Given this list of marker genes NMT2, INTS2, CEP170 (centrosomal protein 170), CNOT6, MMD, TENT4B, KCNMA1, GCLC, CSMD3, TDRD5, PTPRT, TTC13, CCDC138, TBC1D19, GALNT1 (NCBI Gene Id 2589), PPARGC1A, LAMC1, PDZRN3, AP3B1, PCCB, ABCB9, BPTF, FBXO48, MIER1, EPHA7, WTAP, PI4KAP2, TOP1, HOXA5, FBXO22, HOXA1, B4GALT3, PCDH11X, RAP1A, EPN2, CYCS, SLC25A3, FAM91A1, UST, CCAR1, HNRNPR, PARL, BRWD1, RSBN1, HIVEP1, FGF7P6, ARL8B, TBC1D25, HP1BP3, TRIP12, PRPF38B, FOXN3, MROH7, ACE, KCNIP2, SLC17A5, PCDH11Y, CLINT1, SFRP2, TIA1, WDR45B, YTHDF3, UBE2D2, GABPB2, STMN4, FGF7, TMEM33, WDR20, CEP135, PPM1A, UBR5, SCAMP1 (NCBI Gene Id 9522), DLEC1, GATA3, STK38, HIF1A, AZIN1, ARRDC4, HERC4, ZC3H6, CLYBL, MXI1, RSRP1, E2F3, JAK2, RAD9A, TNRC6B, CENPJ, CNIH1, EPC2, GRB2, SRP54, NFIB, MSL2, SRSF3, CLIP1, PHF20L1, KIF16B (NCBI Gene Id 79757), PAK4 (NCBI Gene Id 115291), STYX, SMG5, MARK3, CHMP5, NUP35, TTN (NCBI Gene Id 7847), SLA, PLAGL2, ZMIZ1 (NCBI Gene Id 57178), CDK17, VKORC1L1, UBR1, DNAJC5, FGF7P3, ANKRD12, here is a description of the gene set: Genes having at least one occurence of the motif ATCATGA in their 3' untranslated region. The motif represents putative target (that is, seed match) of human mature miRNA hsa-miR-433 (v7.1 miRBase). species: Homo sapiens Human Gene Set: ATCATGA_MIR433